The following is a description of a gene set: The process that results in the return of an insulin receptor to an active state at the plasma membrane. An active state is when the receptor is ready to receive an insulin signal. Internalized insulin receptors can be recycled to the plasma membrane or sorted to lysosomes for protein degradation. Mouse Gene Set: GOBP_INSULIN_RECEPTOR_RECYCLING studied in species Mus musculus, and this is the list of marker genes: Ptpn1, Ide, Ctsd, Sorl1, Ptpn2